Given this list of marker genes Mfap5, Erlin2, Mybl2, Plp1, Slc30a3, Nav2, Col11a1, Edaradd, Ankrd13b, Otub2 (NCBI Gene Id 72396), Col5a3, Col1a1, Serpinh1, Hapstr1, Zfp36, Col19a1, Mxd1, Dicer1, Palm, Foxj2, Mycn, Vash1, Wdfy1, Nckap5, Sms, Nfat5, Proser1, Col4a6, Dgkd, Brwd3, Adam12, Pcdhac1, Iffo1, Nexmif, Shroom2, Usp37, Rab6b, Ybx3, Rnpepl1, Kdm2a, Eif4e2, Tlcd3b (TLC domain containing 3B), Or2ag2b, Atad2b, Serpina1f, Nktr, Taf5, Ubn1, Dbt, Matn3, Zfp512b, Fras1, Slc19a3 (NCBI Gene Id 98426), Zfp36l1, Zfx, Naa40, Atp1b4, Ppm1e, Aco1, Col4a2, Csrnp2, Ppp1r1c, Ak3, Rfx7 (NCBI Gene Id 77004), Pgap2, Kcnip2, Carmil1, Fam168b, Bak1, Nfia, Slc31a1, Zbtb34, Pcdha7, Atp2b4, Abcb6, Arvcf, Hormad1, Dnmt3a, Pan2 (PAN2 poly(A) specific ribonuclease subunit), Eml6, Bmf, Akt3, Clock, Pxdn, Kmt5a (lysine methyltransferase 5A), Col8a1, Dnmt3b, Rere, Psma3, Sgk1, Zbtb47, Rab30, Map6, Rapgefl1, Eml4, Prkra, Ldlrap1, Adipor1, Arf2, Wbp1l, Tmem183a, Gid8, Pcsk5, Mfap3, Pcdha12, Grip1, Cldn1, Dennd1b, Zdhhc21, Sh3pxd2a, Rmnd5a, Zfp704, Nrep, Abce1, Jarid2, Igsf9b, Tet3, Nap1l3, Tet1, Lox, Dtwd2, Rev3l, Tubb2a, Tfeb, Tnrc18, Icos, Mtmr4, Adamts17, Dpysl5, Pcdha6, Iqschfp, Col2a1, Trim63, Adamts7, Has3, Elovl4, Hbp1, Ddx3x, Eml5, Kif26a, Gpx7, Amot (angiomotin), Pgap1, Slc25a3, Gpr156, Smim17, Frat2, Tmtc3, Rnd3, Pcdha8, Ric1, Pdik1l, Tfec, Mbtd1, Klhl28, Col15a1, Zmiz1, Syn3, Zfp346, Smtnl2, Slc4a7, Blm, Entpd7, Cpsf7, Rexo1, Mtfr2, Fbxw7, Amer1, Dcun1d4, Erc1, Pcdha11, Enho, Nkiras2, Gxylt2, Taf7, Klf4, Sp1, Pcdha5, Stard8, Sppl2b, Eomes, Il1rap, Sh3bp5l, Pi15, Pcdha10, Gtpbp2, Fer, Adamts2, Calcr, Tmem169, Igf1, Etv4, Pcdha2, Ttc9, Ppic, Pcdhac2, Adamts10, Chsy1, Ccdc28b (coiled coil domain containing 28B), Narf, Ifi30, Dynlt1b, Pcdha3, Cd276, Adam19, Arpp19, Stmn2, Mex3b, Ccser2, Zbtb10, Tnfrsf1a, Gpcpd1, Kdm4b, Rest, Nav1, Ppp1r3d, Sypl2, Eln, Fbxw9, Map4k4, Nasp, Col4a1, Crispld1, Zmym2, Arrdc3, Rarb, Kcna5, Nsd1, Col4a5, Traf4, Fam167a, N4bp2l1, Morf4l1, Pten, Eva1b, Tcf4, Camk4, Slc43a2, Col25a1, Lysmd1, Col6a3, Hspg2, Dusp2, Ptbp3, Unc13b, Efna5, Npas3, Col4a3, Fstl1, D630045J12Rik, Slc5a8, Fam241a, Tpk1, Pcdha1, Gpr161, Senp1, Apc, Gpr82, Hmcn1, Robo1, Mapkbp1, Gng12, Col27a1, Natd1 (N-acetyltransferase domain containing 1), 0610030E20Rik, C1qtnf6, Hecw1, Ythdf3, Mark3, Morf4l2, Col3a1, Ky, Vegfa, Fermt2 (NCBI Gene Id 218952), Wdcp, Glis2, Stx16, Col5a1, Sestd1, Traf3, Lin7a, Samd4, Zfp91 (NCBI Gene Id 67567), Rnf19a, Hcn1, Tpm1, Nup160, Purg, Pcdha9, Asxl3, Tet2 (tet methylcytosine dioxygenase 2), Bltp3b, Kmt5c, Dio2, Adamts6, Dlg2 (NCBI Gene Id 78880), Col22a1, Zbtb5, Kdm5b, Sparc, Elf2, Dpysl2, Kif26b, Fem1b (NCBI Gene Id 14155), Dcx, Slk, Tspan4, Smurf2, Otud4, Hrk, Pmp22, Atrn, Bach2, Dgkh, Ccnyl1, Smpd3, Ccnl2, Timd2, Sidt1, Trib2, Akap5 (A kinase anchor protein 5), Col7a1, Tarbp1, Wwtr1, Zfp282, Mcl1, Nkapd1, Jazf1, Pdgfa, Hdac4, Lif, Uaca, Pcgf3, Lpl, Gpr37, Pcdha4, Adamts9, Adamts16, Col5a2, Trafd1, Bmt2, Col9a1, Cdk6, Ythdf1, Chfr, Tll1, Fscn1, Dpp3, Fubp1, Ireb2, Pik3r1, Fbn1, Adamts18, Zfp568, Ppm1d, Eps15, Xkr7 (X-linked Kx blood group related 7), here is a description of the gene set: from publication Chen Y, Wang X (PMID 31504780) species: Mus musculus Genes predicted to be targets of miRBase v22 microRNA mmu_miR_29c_3p in miRDB v6.0 with MirTarget v4 prediction scores > 80 (high confidence targets). Mouse Gene Set: MIR_29C_3P